The following is a description of a gene set: Human Gene Set: GOBP_PYRIMIDINE_NUCLEOSIDE_CATABOLIC_PROCESS The chemical reactions and pathways resulting in the breakdown of one of a family of organic molecules consisting of a pyrimidine base covalently bonded to a sugar ribose (a ribonucleoside) or deoxyribose (a deoxyribonucleoside). species: Homo sapiens, and this is the list of marker genes: UPB1 (beta-ureidopropionase 1), DPYD, CDA (NCBI Gene Id 978), APOBEC3G, UPP2, CDADC1, AICDA, DCTD, APOBEC3C, UPP1